The following is a description of a gene set: Network of differentially expressed myeloid genes centered around CEBPA. studied in species Mus musculus from publication Kamikubo Y, Zhao L, Wunderlich M, Corpora T, Hyde RK, Paul TA, Kundu M, Garrett L, Compton S, Huang G, Wolff L, Ito Y, Bushweller J, Mulloy JC, Liu PP (PMID 20478528) Human Gene Set: KAMIKUBO_MYELOID_CEBPA_NETWORK Dominant RUNX1 inhibition has been proposed as a common pathway for CBF leukemia. CBF beta-SMMHC, a fusion protein in human acute myeloid leukemia (AML), dominantly inhibits RUNX1 largely through its RUNX1 high-affinity binding domain (HABD). However, the type I CBF beta-SMMHC fusion in AML patients lacks HABD. Here, we report that the type I CBF beta-SMMHC protein binds RUNX1 inefficiently. Knockin mice expressing CBF beta-SMMHC with a HABD deletion developed leukemia quickly, even though hematopoietic defects associated with Runx1-inhibition were partially rescued. A larger pool of leukemia-initiating cells, increased MN1 expression, and retention of RUNX1 phosphorylation are potential mechanisms for accelerated leukemia development in these mice. Our data suggest that RUNX1 dominant inhibition may not be a critical step for leukemogenesis by CBF beta-SMMHC., and this is the list of marker genes: GLRX, CEBPA, LGALS1, ALDH2, ANXA1, LYZ, SPINT2, PRTN3, ITGAM, IRF8, CD177, LCN2, HDC, FPR2, RAB31, CAMP, S100A9, PGD, LBP, MMP8, CSF2RA, HP, IL18, DGAT2, CASD1, CYBB, ADGRE1, SERPINB1, S100A8, LTF